The following is a description of a gene set: Human Gene Set: GOMF_ACTIVIN_RECEPTOR_ACTIVITY_TYPE_I studied in species Homo sapiens Combining with activin-bound type II activin receptor to initiate a change in cell activity; upon binding, acts as a downstream transducer of activin signals., and this is the list of marker genes: TGFBR2, ACVRL1, ACVR1C, ACVR1, ACVR2A, TGFBR1, ACVR1B